Given this list of marker genes TWIST1, FGFR3 (NCBI Gene Id 55546), POLR1D, MAD1L1 (NCBI Gene Id 8379), COL2A1, SLC26A2, ZBTB20, KRAS, IDH1, ZNF462, PTPN11, HGD, GNAI3, DHX30, IDH2, UBA1, POLR1C, PTCH1, TRAPPC2, TGIF1, ABCC6, PEX2, HLA-B, POLR1B, MGP (matrix Gla protein), FGFR1, F8, HS2ST1, FGFR2, PUF60, STEEP1, ENPP1, TNFRSF11B, ANKH, FLNB, PEX5, EXT1, NSD2, TCOF1, DDR2, TCTN3, EXT2, PTH1R, EDN1, SIX3, PLCB4, LBR, here is a description of the gene set: Abnormal cartilage morphology Human Gene Set: HP_ABNORMAL_CARTILAGE_MORPHOLOGY species: Homo sapiens Any morphological abnormality of cartilage.